Given this list of marker genes Slc24a4, Nsmf, Myo1c, Mup3, Dennd4c, Atp1a1, Reg1, Rest, Ncoa5, Kank1, Cnot3, Greb1l, Cga, Smarcc1, Carm1, Ugt1a6a, Foxo1, Ddx5, Prkcb, Nr1d1, Gpr173, Serpina1b, Inhbb, Hdac8, Nr1h2, Csk, Csrp3 (cysteine and glycine-rich protein 3), Card9, Mir125a, Ret, Kdm6a, Arsb, Wnt7a, Cacybp, Scnn1b, Gja1, Med1, Max, Sdc1, Pak1, Nr1h3, C1qtnf12, Atp1a3, Eif4ebp1, Fbxw8, Pdcd7, Wt1, Pxn, Rbm4, Bcl2, Mir206, Gkn2, Agrp, Adipor2, Pdgfrb, Zfp747l1, Uri1, Pip4k2c, Ramp2, Reg2, Ncoa4, Rnf6, Ncoa3, Msi1, Irs4 (insulin receptor substrate 4), Hmga2, Adcy6, Lbh, Scgb1a1, Anxa3, Stc1, Acvr1c, Ccna2, Pld1, Ccl21e, Zbed3, Eif4e, Krt19, Tyk2, Cyfip1, Ccl19-ps6, Ghsr, Trpv1 (transient receptor potential cation channel, subfamily V, member 1), Reg3a, Rab31, Ptger2, Prkcd, Zdhhc7 (NCBI Gene Id 102193), Pik3r2, Shq1, Mir493, Grb2, Aanat, Gprin3, Fas, Fbn1, Stk11, Ar, Dnaaf4, Prkce, Aqp1, Strap, Gjb2, Otc, Actn2, Hras, Ezh2, Acta1, Bcar3, Mir297-1, Il17a, Fhl2 (NCBI Gene Id 96862), Bmp7, Cyp7b1, Il1rn, Pfkfb1, Uprt, Ccl2, Serpina3h, Ifnb1, Eif2b3, Epha10, Esrrg, mt-Cytb, Mmp2, Rxfp2, Cpeb2, Ptger1, Nos3, Zfp36, Pcsk9, Slc30a10, Adm, Gpr22, Mme, Akr1c19, Tnfsf10, Mst1r, Igfbp2, Npr2, Xbp1, Ppara, Bche, Mapk3, Tbx1, Hmgb2, Rab10, Ctbp2, Ugcg, Ang4, Hpn, Gcnt1, Maob, Igfbp5, Esr2, Cyp26a1, Cyp27b1, Arid5a, Rxrg, Ptpra, Gsk3b, Fgfr3, Bcas3, Trip4, Rps6, Epo, Cyp26b1, Lats2, Mbp, Grk2, Rcan1, Prkaca, Tnf, Gatm, Nr5a1, Mkks, Srd5a2, Pdpk1, Cd38, Rhoq, Tyro3, Wdtc1, Cacna1a, Asxl1 (NCBI Gene Id 228790), Junb, Cdkn1b, Ucn2, Oprk1, Adra2a, Sts, Fut7, Stk39, Capn1, Serpina3m, Egr2, Prokr1 (prokineticin receptor 1, NCBI Gene Id 58182), Hsd11b2, Snai2, Inhba, Akap8, Kat2b (NCBI Gene Id 320956), Cnot2, Zfp36l1, Hcrtr1, Daxx, Gpr83, Snx5, Ctsb, Rhoa, Tgfb3, Mir708, Stat5b, Cyp1b1, Ace, Mgarp, Trarg1, Mmp19, Ins2, Blvra, Otop1, Scnn1a, Tac1, Comt (catechol-O-methyltransferase), Qrfprl, Akt2, Mir143, Glp2r, Ddit4, Ggh, Ang, Sfrp1, Mup4, Zfp366, Gh, Uchl3, Sorl1, Cps1, Lepr, Ep300, Cela2a, Lep, Slc10a1, Abcc2, Lpl, Ufl1, Star, Lpin1, Gclm, Cav1, Hdac1, Fosl2, Ptk2b, Acat1, Prokr2, Fos, Epm2aip1 (NCBI Gene Id 77781), Mir466, Agtr1a, Tek, Tcf12 (NCBI Gene Id 319985), Echdc3, Ccr7, Agtrap, Wbp2, Pcna, Timp2, Insrr, Casp9, Cldn1, Bmal1, Pnpt1, Ywhah, Bmp4 (NCBI Gene Id 12159), Sstr5, Jund, Nefl, Ugt1a1, Adra1b, Scnn1g, Sirt6, Naip1, Khk, Ctsk, Inppl1, Mir574, Pappa, Rela, H2az1, Mertk, Rb1, Adcy8, Agxt, Gpx1, Rbfox2, Itgb3, Mapkap1, Anxa1, Stc2, Sult1a1, Htr1b, Stat5a, Tbl1x, Lncbate10, Adipoq, Sh2b2 (NCBI Gene Id 54699), Pias2, Hcrtr2, Slc2a1, Ctsl, Pten, Epha2, Ube3a, Smyd3, Mt3, Kcnj8, Umodl1, Slc39a14, Tat, Lats1, Foxl2, Ccl19-ps3, Zbtb7a, Sstr2, Nfe2l2, Agl, Fgb, Ptpn2, Mdm2, Cited4, Ptpn11, Jak1, Rarb, Hsp90aa1, Ucn3, Il3, Prkar1a, Pax6, Ren1, Usf1, Idh1, Safb2, Mirlet7e, Hdac6, Tacr1, Flt4, Cited1, Il18, Ptgfr, Ptgds, Sp7, Itga3, Slc12a3, Bmi1, Ucp2, Musk, Nkx2-2, Nck1, Rarg, Ptpru, Skp2, Fosl1 (NCBI Gene Id 14283), Cldn4, Paqr8, Foxo4, Prkcq, Mstn, Ucn, Lonp1, Chuk, Jak3, Akr1c6, Cat, Ncoa2, Socs3, Nodal, Prlh, Ptprf, Atp2a2, Ccl19-ps1, Mef2c, Smarca4, Pdk2, Cd2ap, Gck, Bglap2, Irs3, Atp2b1, Igfbp1, Ddr1, Mir423, Srsf5, Ncl, Ufm1, Sord, Serpina3c, Mir195a, Timp1, Kcnq1, Mas1, Ppard, Appl2, Alad, mt-Nd3, Cpn1, Spp1, Ass1, Bmp6, Zfp764, Mc4r, Sstr3, Bbs4, Phex (phosphate regulating endopeptidase homolog, X-linked), Gdf15, Pck2, Nucks1, Hoxa11, Tshr, Ccl19-ps5, Mat2a, Ncor2, Hnmt, Npc1, Sva, Lmo3, Crhr1, Acsbg1, Bglap3, Mtor, Rdx, Cry2, Sstr1, Ccl21a, Lrp5, Crk, Fgfr2, Ctnnb1, Pklr, Prkdc, Serpina3i, Flt1, Rangap1, Mir3065, Inpp5k, Cited2 (NCBI Gene Id 17684), Lpin3, Fshr, Ptprj, Nr4a3, Ptges3, Epha4, Abcc9, Prkaa1, Slc27a1 (solute carrier family 27 (fatty acid transporter), member 1), Ccl21f, Mir142, Lpin2, Trim63, Il10, Abcb11, Gpld1, Mir338, Pid1, Axin2, Nr1h4, Abca3, Cfl1, Blvrb, Shoc2, Abcc1, Sstr4, Ephb1, Naip6, Rxfp1 (relaxin/insulin-like family peptide receptor 1), Mup2, Cuzd1, Kdm5d, Ahcyl1, Wnt1, Acaca, Gpr82, Cxcl2, Phb1 (prohibitin 1), Rbbp5, Hmgcs2, Smad6, Vps54, Calr, Ccl21d, Slc27a4, Hnrnpk, Edn1, Alpl, Paqr7, Ptpre, Klf15, Gnai1, Slco1b2, Prlr, Creb1, Mup5, Ddr2, Sst, Scly, Ncf2, Hadha, Ccl21b, Klf2, Fkbp4, Aldh1a3, Tgfbr1, Pou4f2, Epha6, Fech, Oxt, A2m, Myod1, Pld2, Snrpn, Cybb (cytochrome b-245, beta polypeptide), Slit3, Crkl, Nr0b1, Slc26a6, Ror2, Smad3, Ppargc1a, Cdkn1a, Pgr, Ndel1, Nucb2, Cldn18, Ccnd3, Jak2, Calcoco1, Mir207, Osbpl8, Dag1, Apoc3, Agtr2, Cul7, Fer, Uba5, Serpina1c, Eif2b1, Ocstamp, Pparg, Ceacam2 (CEA cell adhesion molecule 2), Sik2, Cckar (cholecystokinin A receptor), Cry1, Hmgb1, Rbp4, Ceacam1, Gata4, Or51e2, Ang5, Aldh3a1, Fam114a1, Mir126a, Trerf1, Ccnd1, Jun, Bcar1, Eprs1, C1qtnf9, Tomm70a (NCBI Gene Id 70049), Nfkb1, Foxc2, Ghrhr, Gcgr, Ikbkb, P2ry4, Atp1a2, Cnot1, Ppp3ca, Prkcz, Ppp5c, Pim1 (NCBI Gene Id 18712), Serpina3g, Adrm1, Asns, Apc, Mup11, Lcat, Fbp1, Irs2, Padi2 (peptidyl arginine deiminase, type II), Bsg, Ppp1r9b, Nr3c2, Aifm1, Hdac9, Atp2a1, Atp5f1a, Ctnna1, Htr7, Rbx1, Igf1r, Lta4h, Egfr, Rps6kb2, Camk2a, Klf9, Btg2, Gba1, Scgb2a2, Sfr1, Map1b, Nkx2-1, Srebf2, Prcp, Rwdd1, Car2, Pde3a, Bckdhb, Eif2b4, Ctsd, Mir672, Retn, Pde4d, Srarp, Casp3, Mir451a, Agtr1b, Btg1, Errfi1, Ang6, Arsa, Hnrnpu, Gata1, Flt3, Rock2, Park7, Akr1c12, Ramp1, Gnai2, Tbx2, Stxbp4, Avpr1a, Grb10, Meak7, Ncor1, Serpina1a, Mzb1, Mir18, Vgf, Ogt, Socs1, Crebrf, Yy1, Ramp3, Zmiz1, Il1b, Isl1, Gpt, Gad2, Zfp106, Lancl2 (LanC (bacterial lantibiotic synthetase component C)-like 2), Per1, Lrrc25, Rbbp7, P2ry6, Socs7, Heyl, Hcls1, Srf (NCBI Gene Id 224821), Rara, Ptk2, Plcb1, Txn2, Sost, Prmt2, Etnppl, Zfp592, Pik3ca, Foxh1, Cyc1, Mir125b-1, Pdk4, Erbb2, Mettl21c, Avpr1b, Crls1, Ins1, Nr3c1, Glb1, Efna5, Sox30, Ghrl, Tnfrsf11a, Trp63, Por, Kdm3a, Gip, Ednrb, Me1, Cst11, Acaa1a, Akt3, Pde3b, Kcnma1, Trim72, Ang2, Phip, Nr5a2, Lcn8, Prkd1, Syap1, Safb, Ucp3, Mb, Npffr1, Got1, Axl, Ankrd26, Reg3g, Rps6kb1, Srebf1, Pck1, Nedd4, Slc2a4, Prkca, Adh1, Esrra, Zfp536, Col6a1, Adora2b, Vdr, Snw1, Iqgap1, Reg3b, Mtcl2, Tnc, Ednra, Eif6, Insr, Brip1, Nudc, Lrp2, Mapk14, Tgif1, Nkx3-1, Hmga1, Sos1, Prkaa2, Serpina3n, Gabrb1, Tsc1, Mapk1, Ephb4, Foxo3, Tnfsf4, Serpina3k, Adam9, Kbtbd2, Cad (NCBI Gene Id 69719), Opa1, Ahsg, Gria1, Tmf1, Dsg2, Insig1, Hspa8, Parp1, Met, Slc34a2, Gnas, Phb2, Acbd7, Serpinf1, Rab13, Tsc2, Mmp13, Crhbp, Aldob, Mup1, Tns2, Irf1, Tnfrsf11b, Igf2, Trib3, Avpr2, Ptger4, Sgk1, Abcb1a (ATP-binding cassette, sub-family B member 1A), Ptprv, Rab8a, Dhrs3, Pitx2, Hmox1, Ghr, Ptf1a (pancreas specific transcription factor, 1a), Dhh, Cntnap2, Dnai1, Ntrk3, Trim24, Acsl1, Akr1c18, Brca1, Cdo1, Uso1, Cdk2, Ostn, Epha7, Rap1gds1, Strn3, Gpi1, Prkcg, Braf, Mir223, Akr1c20, Kank2, Nos1, Ddx17, Ptgdr, Sox10, Timp4, Th, Ros1, Cnot9, Vps11, Sgcb, Gstm5, Col3a1, Rnf14, Csn1s1, Mbd5, Nr1d2, Scn11a, Myo5a, Ccl19, Gata6, Shc1 (src homology 2 domain-containing transforming protein C1), Ereg, Fkrp, Ddrgk1, Pagr1a, Rac1, Abca2, Serpina1e, Nkx6-1, Sorbs1, Stat4, Ephb2, Appl1, Zfp764l1, Leprot, Prl, Adipor1, Rxrb, Cd24a, Timp3, Rerg, Raf1, Nr4a2, Clock, Insig2, Epha3, Steap2, Src, Gpr150, Gsk3a, Zfp36l2, Fgf23, Mn1, Il6 (NCBI Gene Id 16193), Npas4, Thra, Ggcx, Ephb3, Gpam, Gdnf, Ash2l, Hes1, Galp, Yap1, Usp26, Tie1, Hsf1, Thrb, Notch1, Gphb5, Tbc1d4, Sp1, Sra1, Pcsk1, Eif4ebp2, Erfe, Eef2k, Cyp11b2, Vps18, Ucp1, Fosb, Zfp747, Kit, Hadh, C2cd5, Ncoa1, Pomc, Actn4, Fam107a, Rps6-ps4 (ribosomal protein S6, pseudogene 4), Sirt1, Sesn3, Mfn2, Nqo1, Tcf21, Ptgs2, Reg3d, Srsf6, Gper1, Eif2b5, Pml, Qrfpr, Gclc, Igf1, Sos2, Slc2a8 (NCBI Gene Id 56017), Marcks, Abhd2, Kdm4c, Ntrk2, Stxbp3, Akr1c13, Tgfbr3, Serpina3f, Serpina12, Hhex, Sort1 (sortilin 1), Mir148a, A1bg, Stat6, a, Rock1 (NCBI Gene Id 68785), Gli3, Agt, Oxtr, Arid1a, Stat2, Akt1, Pelp1, Acod1, Fbxo32, Angptl3, Cyp11b1, Cp, Cul3, Epha5, Foxa1, Areg, Gnrh1, Pik3r3, Csf1r (colony stimulating factor 1 receptor), Ccl19-ps4, Socs2, Ptafr, Trim68, Tgfb1, Calcr, Bdnf (brain derived neurotrophic factor), Srsf3, F7, Vps13c, Zbtb7b, Lhcgr, Brd8, Dnaja1, Uqcrfs1, Fgfr4, Kmt2e, Tyms, Pf4, Esrrb (estrogen related receptor, beta), Anxa5, Pax8, Mir21a, Pkm, Nono, Map3k7, Eif2b2, Lnpep, Mir494, Ube2l3, Plcd1, Epha1, Tfpi, Ffar3, Vamp2 (vesicle-associated membrane protein 2), Pip4k2b, Lox, Ubr5, Acr, Capn10, Ctsh, C2, Col1a1, Bglap, Esr1, Pdcd4, Kmt2d, Sesn2 (NCBI Gene Id 230784), Gata3, Itga2, Slc26a5, Crh, Stat3, Tgfb2, Txnip, Kl, Cab39, Slc9a1, Pik3r1, Ppargc1b, Dhcr24, Fgfr1, Naip2, Pdgfra, Glp1r, Nr2c1, Kdr, Nos2, Ptpn1, Crhr2, Gpr21, Akap13, Csnk2b, Foxp1, Enpp1, Obp2a, Ywhag, Wnt10b, Mir146, Sco1, Serpina1d, Grb7, Gnrhr (gonadotropin releasing hormone receptor), Trim25, Ache, Pip4k2a, Egr1, Ntrk1, Gcg, Mmp14, Cpeb1, Taf7 (TATA-box binding protein associated factor 7), Adcyap1, Alk, Erbb4, Prkci, Gkap1, Nr4a1, Scap, Irs1, Aldh1a2, Epha8, Map2k1 (mitogen-activated protein kinase kinase 1), Vwa2, Dab2, Ufsp2 (NCBI Gene Id 66429), Ide, Npffr2, Adra1a, Stat1, Rpl27, Mir486 (NCBI Gene Id 723876), Ugt1a6b, Mir145a, Rxra (retinoid X receptor alpha), Tspo, Leprotl1, Bbs2, Hoxa10, Trpv4, Gstp1, Ltk (NCBI Gene Id 17005, leukocyte tyrosine kinase), Grb14, Rarres2, Cyp11a1, Mir155, Pdx1, Trh, Cav2, Lyn, Slc25a33, here is a description of the gene set: Mouse Gene Set: GOBP_RESPONSE_TO_HORMONE Any process that results in a change in state or activity of a cell or an organism (in terms of movement, secretion, enzyme production, gene expression, etc.) as a result of a hormone stimulus. studied in species Mus musculus